The following is a description of a gene set: Human Gene Set: REACTOME_SIGNALLING_TO_P38_VIA_RIT_AND_RIN species: Homo sapiens Signalling to p38 via RIT and RIN, and this is the list of marker genes: BRAF, RIT2, NTRK1 (NCBI Gene Id 7825), NGF, RIT1